Given this list of marker genes MSH6, RMI2 (NCBI Gene Id 116028), MSH3, TCF7L2, MSH2, AXIN2, ZMPSTE24, here is a description of the gene set: species: Homo sapiens Any process involved in sustaining the fidelity and copy number of DNA repeat elements. Human Gene Set: GOBP_MAINTENANCE_OF_DNA_REPEAT_ELEMENTS